The following is a description of a gene set: species: Mus musculus Mouse Gene Set: GOBP_OTIC_VESICLE_FORMATION The process resulting in the transition of the otic placode into the otic vesicle, a transient embryonic structure formed during development of the vertebrate inner ear., and this is the list of marker genes: Hesx1 (homeobox gene expressed in ES cells), Fgf8, Tcap, Fgf3, Cep290, Fgfr2, Sox9, Fgf10